The following is a description of a gene set: studied in species Mus musculus This event has been computationally inferred from an event that has been demonstrated in another species.<p>The inference is based on the homology mapping from PANTHER. Briefly, reactions for which all involved PhysicalEntities (in input, output and catalyst) have a mapped orthologue/paralogue (for complexes at least 75% of components must have a mapping) are inferred to the other species. part of: RHO GTPase cycle Reactome Pathway: RHOV GTPase cycle electronically inferred by orthology from the curated human pathway, and this is the list of marker genes: Epha2, Pak6, Zfp512b, Wdr6, Rhov, Cdc42, Vangl1, Pak4, Txnl1, Arhgef7, Tpm3, Arhgap12, Depdc1b